Given this list of marker genes Ncaph, Cdkn2c, Haus3, Hmgb3, Lgals1, Hnrnpab, Enpep, Mcm3, Prep, Ttk, Dtl, Anp32e, Rrm2, Prdx4, Prc1, Dlgap5, Dnmt1, Top2a, Rad54l (RAD54 like (S. cerevisiae)), Ccna2, Gm4739, Iqgap3, Cdkn1a, Cenpl, Mcm2, Uck2, Mcm7, Smc4, Slc29a1, Tuba1a, Ccnb1, Ube2c, Ramp1, Smarca5, Cdca5, Kpna2, Cenpa, Cdc45, Dck, Rbbp4, Slc16a1, Gm4870, Cdca3, Lmnb1, Igll1, Rag1, Cdc20, Ckap5, Nusap1 (nucleolar and spindle associated protein 1), Cdca7, Ptgr1, Ezh2 (enhancer of zeste 2 polycomb repressive complex 2 subunit), Mki67, Kifc5b, E2f8, Cdkn3, Slbp, Mcm6, Melk, Smc2, Hmgb1, Lig1, Gsn, Hnrnpa3 (NCBI Gene Id 69921), Cks1b, Stmn1, Ccnb2 (NCBI Gene Id 235460), Rad51, Txn1, Rrm1, Cdk1, H2ax, Prim1, Mcm10 (NCBI Gene Id 99184), Hmgn2, Xrcc6, Tmpo, H2ac6, Pcna, Chek1, Actn4, Smarca4, H2az2, Hjurp, Mthfd2, Pck2, Nek2 (NCBI Gene Id 98226), Cbx1, Tuba1b, Tubb4b, Tubb5, here is a description of the gene set: from publication Mori S, Rempel RE, Chang JT, Yao G, Lagoo AS, Potti A, Bild A, Nevins JR (PMID 18922927) Down-regulated genes in the B lymphocyte developmental signature based on expression profiling of lymphomas from the Emu-myc transgenic mice: the immature B stage. studied in species Mus musculus The Emu-myc transgenic mouse has provided a valuable model for the study of B-cell lymphoma. Making use of gene expression analysis and, in particular, expression signatures of cell signaling pathway activation, we now show that several forms of B lymphoma can be identified in the Emu-myc mice associated with time of tumor onset. Furthermore, one form of Emu-myc tumor with pre-B character is shown to resemble human Burkitt lymphoma, whereas others exhibit more differentiated B-cell characteristics and show similarity with human diffuse large B-cell lymphoma in the pattern of gene expression, as well as oncogenic pathway activation. Importantly, we show that signatures of oncogenic pathway activity provide further dissection of the spectrum of diffuse large B-cell lymphoma, identifying a subset of patients who have very poor prognosis and could benefit from more aggressive or novel therapeutic strategies. Taken together, these studies provide insight into the complexity of the oncogenic process and a novel strategy for dissecting the heterogeneity of B lymphoma. Mouse Gene Set: MORI_IMMATURE_B_LYMPHOCYTE_DN